Given this list of marker genes CDC25C, MAPK15 (mitogen-activated protein kinase 15), PLCB1, OOEP, DAZL, PIWIL2, PRDM9, UBE2B, SIRT2, DMRT1, MSX1 (NCBI Gene Id 4487), LFNG, OVOL1, NPR2, CDC25A, WNT4, WNT5A, YTHDC2, MSX2, INSR, RBM46, NPM2, CDC25B, STRA8, RAD51AP1, MEIOSIN, MEIOC, here is a description of the gene set: species: Homo sapiens Human Gene Set: GOBP_POSITIVE_REGULATION_OF_MEIOTIC_CELL_CYCLE Any process that activates or increases the frequency, rate or extent of progression through the meiotic cell cycle.